Given this list of marker genes SLC29A4, PLA2G3, VAMP7, SNX6, SLC22A2, SNX4, BTK, SNAP23, RAB44, VAMP8 (vesicle associated membrane protein 8), EDN1, VAMP2, VAMP3 (vesicle associated membrane protein 3), SLC22A3 (solute carrier family 22 member 3), LYN, CSF2, SLC18A2, here is a description of the gene set: studied in species Homo sapiens The directed movement of histamine into, out of or within a cell, or between cells, by means of some agent such as a transporter or pore. Histamine is a physiologically active amine, found in plant and animal tissue and released from mast cells as part of an allergic reaction in humans. Human Gene Set: GOBP_HISTAMINE_TRANSPORT